Given this list of marker genes Acta2, Dgat1, Lep, Pdgfrb, Rps6ka1, Ddr2, Fgfr1, Smo (smoothened, frizzled class receptor), Nr1d1, Pdgfb, Cygb, Rian, Gclc, Myb, here is a description of the gene set: studied in species Mus musculus Mouse Gene Set: GOBP_REGULATION_OF_HEPATIC_STELLATE_CELL_ACTIVATION Any process that modulates the frequency, rate or extent of hepatic stellate cell activation.